The following is a description of a gene set: Abstract: Trastuzumab-induced cardiotoxicity (TIC) is a common and serious disease with abnormal cardiac function. Accumulating evidence has indicated certain non-coding RNAs (ncRNAs), functioning as competing endogenous RNAs (ceRNAs), impacting the progression of cardiovascular diseases. Nonetheless, the specific involvement of ncRNA-mediated ceRNA regulatory mechanisms in TIC remains elusive. The present research aims to comprehensively investigate changes in the expressions of all ncRNA using whole-transcriptome RNA sequencing. The sequencing analysis unveiled significant dysregulation, identifying a total of 43 circular RNAs (circRNAs), 270 long noncoding RNAs (lncRNAs), 12 microRNAs (miRNAs), and 4131 mRNAs in trastuzumab-treated mouse hearts. Subsequently, circRNA-based ceRNA networks consisting of 82 nodes and 91 edges, as well as lncRNA-based ceRNA networks comprising 111 nodes and 112 edges, were constructed. Using the CytoNCA plugin, pivotal genes - miR-31-5p and miR-644-5p - were identified within these networks, exhibiting potential relevance in TIC treatment. Additionally, KEGG and GO analyses were conducted to explore the functional pathways associated with the genes within the ceRNA networks. The outcomes of the predicted ceRNAs and bioinformatics analyses elucidated the plausible involvement of ncRNAs in TIC pathogenesis. This insight contributes to a better understanding of underlying mechanisms and aids in identifying promising targets for effective prevention and treatment strategies. from publication Xie S, Zhou N, Su N, Xiao Z, Wei S, Yang Y, Liu J, Li W, Zhang B (PMID 38577019) Mouse Gene Set: XIE_TRASTUZUMAB_CARDIOTOXICITY_MMU_MIR_31_5P_GENES species: Mus musculus, and this is the list of marker genes: Gatad2b, Nfya (NCBI Gene Id 18044), Usf3, Dpagt1, Nlrc3, Serpina3i, Jade2, Tspan5, Ogfod1, Klrk1, Unc93b1, Ptp4a3, Cdc42bpa, Hebp2, Strip2, Rab3c, Ube2k, Plekha6, Nebl, Usp28, Cables1, Ripor2, Ate1, Ppp1r26, Mfsd4b4, Glod4, Ppp6r3, Nsmf, Cbfa2t2, Pnpla2, Tmem248, Midn, Myh14, Extl2